The following is a description of a gene set: Human Gene Set: GOBP_PSYCHOMOTOR_BEHAVIOR studied in species Homo sapiens The specific behavior of an organism that combines cognitive functions and physical movement. For example, driving a car, throwing a ball, or playing a musical instrument., and this is the list of marker genes: GRPR, KCNQ3, GRP, C12orf57, DPP4